The following is a description of a gene set: Undetectable serum immunoglobulin A level at a value < 5 mg/dL (0.05 g/L). species: Homo sapiens Decreased circulating total IgA Human Gene Set: HP_DECREASED_CIRCULATING_TOTAL_IGA, and this is the list of marker genes: CD247, CD3D (CD3 delta subunit of T-cell receptor complex), IVNS1ABP, KNSTRN, SYK, CD3E, PIK3CD, ATP6AP1